Given this list of marker genes ARG1, NLRP3, DENND1B, IFNA2, GATA3, IFNB1, PRKCZ, RSAD2, IL6, TBX21, IL4, CD81, XCL1, here is a description of the gene set: Human Gene Set: GOBP_T_HELPER_2_CELL_CYTOKINE_PRODUCTION species: Homo sapiens Any process that contributes to cytokine production by a T-helper 2 cell.